The following is a description of a gene set: Human Gene Set: GOBP_LEUKOCYTE_ADHESION_TO_VASCULAR_ENDOTHELIAL_CELL studied in species Homo sapiens The attachment of a leukocyte to vascular endothelial cell via adhesion molecules., and this is the list of marker genes: ZDHHC21, ST3GAL4, CCL21, CCL28, PODXL2, MIR92A1, RELA, EXT1, IL6 (NCBI Gene Id 3569), CX3CR1, CHST4, ROCK1, IRAK1, KLF4, CHST2 (carbohydrate sulfotransferase 2), ITGA4, SELL, VCAM1, MIR146A, ELANE, SELPLG (selectin P ligand), ITGB2, JAM2, ITGB1, CCL25, GCNT1, FUT4, NFAT5, CXCL12, SLC39A8, FUT9, MADCAM1, TRAF6, TNF, MIRLET7G, SPN, MIR222, LEP, MIR221 (microRNA 221), MIR21, MIR31, CCR2, ITGB7, FUT7, SELP, MDK, ADD2, ETS1, MIRLET7E, MIR125A, ALOX5, RHOA, SELE, GOLPH3, MIR141, LRG1